Given this list of marker genes Calm2, Calm3, Ppp4r3b, Ppp4r3a, Ppp2r5a, Ppp2r5c, Ppp4r3c2, Gtf2f1, Bmp2, Ppp4r3c1, Ppp2r5e (protein phosphatase 2, regulatory subunit B', epsilon), Slc39a10, Gna12, Ppp2r5b, Igfbp3, Ppp2r5d, Ambra1, Itga1, Phactr4, Ptpa, Cd33, Tiprl, Vrk3, Calm1, Hsp90ab1, B3gat3, here is a description of the gene set: Binds to and increases the activity of a phosphatase. Mouse Gene Set: GOMF_PHOSPHATASE_ACTIVATOR_ACTIVITY studied in species Mus musculus